Given this list of marker genes IGLC1, IGLC6, IGLC7, IGHD, IGLC3, IGKC, here is a description of the gene set: species: Homo sapiens Human Gene Set: GOCC_IGD_IMMUNOGLOBULIN_COMPLEX A protein complex composed of two identical immunoglobulin heavy chains of the IgD isotype and two identical immunoglobulin light chains, held together by disulfide bonds. An IgD immunoglobulin complex may be embedded in the plasma membrane or present in the extracellular space, in mucosal areas or other tissues, or circulating in the blood or lymph.